The following is a description of a gene set: Cell-cell signaling from postsynapse to presynapse, across the synaptic cleft, mediated by a lipid ligand. species: Mus musculus Mouse Gene Set: GOBP_RETROGRADE_TRANS_SYNAPTIC_SIGNALING_BY_LIPID, and this is the list of marker genes: Abhd6, Fabp5, Dagla, Mgll, Cnr1, Plcb1